The following is a description of a gene set: species: Rattus norvegicus Human Gene Set: YAN_ESCAPE_FROM_ANOIKIS We reported earlier that IL-1beta, an NF-kappaB-regulated cytokine, was made by intestinal epithelial cells during detachment-induced apoptosis (anoikis) and that IL-1 was antiapoptotic for detached cells. Since surviving anoikis is a prerequisite for cancer progression and metastases, we are further exploring the link between anoikis and cytokines. Here we determined that multiple genes are expressed following detachment including a number of NF-kappaB-regulated products and therefore aimed to determine whether NF-kappaB signalling plays any role in regulating apoptosis. Using Western blotting, we detected that IkappaBalpha becomes phosphorylated immediately following detachment and that levels of phospho-IkappaBalpha peaked within 20 min. Phosphorylation of IkappaBalpha was followed by Rel A (p65) nuclear translocation. Increased NF-kappaB activity following detachment was confirmed using the detection of NF-kappaB-promoted luciferase gene expression delivered by adenovirus infection. Infection of cells with adenovirus expressing a super-repressor IkappaBalpha protein and pharmacological inhibitors of NF-kappaB resulted in the failure to phosphorylate IkappaBalpha, a more rapid activation of caspases and earlier apoptosis. We also detected that IkappaB kinase alpha (IKKalpha) and not IKKbeta became phosphorylated following detachment. Since IKKalpha is activated by NF-kappaB-inducing kinase (NIK), we overexpressed native NIK using an adenovirus vector that resulted in enhanced phospho-IkappaBalpha and nuclear p65 in detached cells compared to control detached cells but did not result in a significantly greater number of cells surviving to 24 h. We conclude that detachment directly activates NF-kappaB, which, in addition to launching an inflammatory cytokine wave, contributes to a delay in apoptosis in intestinal epithelial cells. Genes up-regulated in IEC-18 cells (intestinal epithelial cells) which avoided anoikis (a form of apoptosis) after detachment. from publication Yan SR, Joseph RR, Rosen K, Reginato MJ, Jackson A, Allaire N, Brugge JS, Jobin C, Stadnyk AW (PMID 16007176), and this is the list of marker genes: ALDH3A1, IRF7, STAT2 (NCBI Gene Id 6773), BCL2L11, DDIT3, NOS2, MX1, IRF1, NFKB1, RSAD2, CXCL10, HLA-DMA, STAT1, CD44, CX3CL1, CCL5, MMP2, C2, CCL20, VCAM1, IL15, EIF2AK2, LTA